Given this list of marker genes Bin1, Lbh, Arhgef3, Ms4a4b, Pycard, Stap1, Rasgrp1, Arhgdib, Clec2d, Lcp2, Tesc, Ski, St8sia4, Nsg2, Cd3g, Smc6, Limd2, Cd27, Pfn1 (NCBI Gene Id 18643), Nav2, Lgals1, Slamf6, Ptpn7, Ankrd44, Coro1a, Klf2, Itgb7, Tnfaip8l2, Ramp1, Lsp1, Emp3, Arhgef1, Add3, AI504432, Smpdl3a, Ucp2, Id3, Pwwp3a, Capg, Mbnl1 (muscleblind like splicing regulator 1), Plec, Ptprcap, Pou2f2, Ccdc50, Itgb2, Hnrnpf, Mxd4, Tespa1, Crip1, Cmtm7, Uba52, Ltb, Macf1, Rac2, Tmsb10, Ifi203, Septin9, Thy1, Arhgap45, Septin7, Apbb1ip, Lck, Bcl2, Tsc22d4 (NCBI Gene Id 78829), Evl, S100a10, Thap3, Ms4a6b, Ephx1, Itgb1 (NCBI Gene Id 70812), Rhoh (ras homolog family member H), Ptpn6, Dgkz, Tspan32, Mob3a, 9930111J21Rik2, Skap1, Grap, Rgs3, Btg2, Trbc2, Fam169b, Bin2, Inpp4b (NCBI Gene Id 234515), Chd3, Ahnak, Ssbp2, Fxyd5, Cd52, Ccdc88c, Mndal, Cd84 (CD84 antigen), Nrp1, Larp1b, Dennd1c, Ctss, Rgs14, Ipcef1, Rgs10, Rarg, Anxa6, Shisa5 (NCBI Gene Id 67794, shisa family member 5), Ighm, here is a description of the gene set: Mouse Gene Set: CUI_TREG_IL1B_RESPONSE_DN studied in species Mus musculus from publication Cui A, Huang T, Li S, Ma A, Pérez JL, Sander C, Keskin DB, Wu CJ, Fraenkel E, Hacohen N (PMID 38057668) Genes negatively differentially expressed in cell type: Treg upon treatment with cytokine: IL-1β in mouse lymph nodes in vivo. Cytokines mediate cell-cell communication in the immune system and represent important therapeutic targets. A myriad of studies have highlighted their central role in immune function, yet we lack a global view of the cellular responses of each immune cell type to each cytokine. To address this gap, the authors created the Immune Dictionary, a compendium of single-cell transcriptomic profiles of more than 17 immune cell types in response to each of 86 cytokines (>1,400 cytokine-cell type combinations) in mouse lymph nodes in vivo. A cytokine-centric view of the dictionary revealed that most cytokines induce highly cell-type-specific responses. For example, the inflammatory cytokine interleukin-1β induces distinct gene programmes in almost every cell type. A cell-type-centric view of the dictionary identified more than 66 cytokine-driven cellular polarization states across immune cell types, including previously uncharacterized states such as an interleukin-18-induced polyfunctional natural killer cell state.